Given this list of marker genes Gnb5, Pth1r, Ucn, Gng3, Sctr, Gipr, Calcr, Calcrl, Pth2r, Gnb1, Calcb, Gng5, Gng4, Vipr2, Gngt2, Ramp2, Gng8, Gng12, Gip, Gnb2, Adgre1, Ramp1 (NCBI Gene Id 77677), Ucn3, Gcg, Vipr1, Gngt1, Ghrhr, Gng10, Adm, Glp2r, Crhr2, Gng2, Pthlh, Ghrh, Pth2, Gng13, Gng11, Crh, Gnb3, Crhr1, Sct, Gng7, Crhbp, Calca, Vip, Gnb4, Adcyap1r1, Gcgr, Glp1r (glucagon-like peptide 1 receptor), Adgre5, Ucn2, Pth, Ramp3, Iapp, Adcyap1, Gnas, Adm2 (adrenomedullin 2), Cd55, here is a description of the gene set: studied in species Mus musculus Mouse Gene Set: REACTOME_CLASS_B_2_SECRETIN_FAMILY_RECEPTORS Class B/2 (Secretin family receptors)